The following is a description of a gene set: Human Gene Set: GOBP_POSITIVE_REGULATION_OF_GLYCOGEN_BIOSYNTHETIC_PROCESS species: Homo sapiens Any process that activates or increases the frequency, rate or extent of the chemical reactions and pathways resulting in the formation of glycogen., and this is the list of marker genes: AKT2, GCK, PPP1CA, PPP1R3B, IRS1, DYRK2, INS, PPP1R3E, SORBS1, EPM2AIP1, IRS2, AKT1, IGF1, IGF2, PTH, PPP1R3G, INSR